Given this list of marker genes Arhgef11, Rhoa, Erbb2, Sema4d, Rock2, Rhob, Plxnb1, Rock1, Rhoc, Rnd1, Arhgef12, here is a description of the gene set: Sema4D induced cell migration and growth-cone collapse studied in species Mus musculus Mouse Gene Set: REACTOME_SEMA4D_INDUCED_CELL_MIGRATION_AND_GROWTH_CONE_COLLAPSE